Given this list of marker genes MRPL16, FAM210B, UBE2F, ODC1 (ornithine decarboxylase 1), BMP2K, CST7, STX3 (syntaxin 3), LINC01160, ILDR1, SIK1, TMBIM1, GUCY1B1, PLPP2, SLC38A2, KCTD17, GAS7, CBLB, ENPP1, CD93, ALAS2, CYFIP1, COL4A1, FRMD4B, TJP2, CKB, RAB11FIP5, PNMA1, FOSB, GCH1, CDC42EP3, GPC1, LGALSL, ANXA2, ITGB8, TAGLN2, PTGER4, RCN1, ABT1, PTPN9, P2RY10, TMEM176B, LGALS1, LDLR, PPP1R15A, NIBAN1, LRRC75B, EFNB2, LUM, SNHG8, BCLAF1, AGO3, CARD10, CTNNA1, PHLDA1, TEC, RRAS, RYR1, REL, RGS2, FANCF, IGSF8, DOCK2, CD82, CXCR4, ITGA1, CLTC, B3GNT5, LPXN, SPRYD7, GADD45B, IL18R1, DGKE, PTTG1, BTG3, ABTB3, APOBEC3B, COL3A1, CREB3L2, TAB2, MAF, SIK2 (salt inducible kinase 2), NUAK2, LUZP1, MAPRE2, MIF4GD, KIF5C, NR1D2, NFIL3, PLEK, TNFSF14, CRIM1, PRXL2C, SQLE, RUNX3, INPPL1, PROS1, GATAD2A, IFITM2, ATXN7L1, ATP2B4, MMP9, KLF12, SAMSN1, PNP, AGPAT4, AOPEP, JCAD (junctional cadherin 5 associated), LATS2, RNF144A, AKNA (NCBI Gene Id 80709), TDP2, LITAF, TTC39C, LRIG1, TSPAN1, DNAJA4, PRNP, MBP, TSC22D2, IMPACT, NAF1, PLS3, PHF6, MDFIC, XDH, ATF6, ANG, DAPK1 (NCBI Gene Id 1612), RAB6B, ZCCHC14, FAM241B, YES1, NFKBIZ, STIM2, FARP1, RUNDC3B, HSPA5, CD38, KLHL11, BCL2A1, HLA-A, ITPRIPL2, RUNX2, HIVEP2, ACOT11, EPSTI1, TBRG4, MYO1F, DNAJB9, KLRG1, EIF4EBP1, PLD2 (NCBI Gene Id 5338), CFD, AKAP13, PTPRB, ATF3, NEFH, ABLIM3, SLC4A7, PLXNC1, NOTCH2 (NCBI Gene Id 55574), SEC24D, TMEM14C, SHLD1, MAFF, HIP1, CAMTA2, PYGL, IER3, SLC25A53, TAS1R1, DYRK3, DENND4A, HOPX, FLT1, PISD, RPL39, ARHGAP21, ANTXR2, PDE7A, ZNF212 (zinc finger protein 212), LDAF1, TRPS1, MYADM, F2R, APP, CASS4, ZDHHC2, GZMB, AKIRIN2, CPT1A, BAIAP3, TSC22D1, CAV1, ATP2B3, KCNK5, RELL1, DPY19L1, ARL4A, IL10, here is a description of the gene set: Genes down-regulated in comparison of thymus conventional T cells versus fat tissue conventional T cells. from publication Feuerer M, Herrero L, Cipolletta D, Naaz A, Wong J, Nayer A, Lee J, Goldfine AB, Benoist C, Shoelson S, Mathis D (PMID 19633656) studied in species Homo sapiens Comparisons of global gene-expression profiles revealed a greater distinction between CD4+ Treg cells and CD4+ conventional (Tconv) T cells residing in abdominal (epidydimal) fat versus in more standard locations such as the spleen, thymus and LN. Human Gene Set: GSE7852_THYMUS_VS_FAT_TCONV_DN